Given this list of marker genes FPGT, GNPNAT1, AMDHD2 (amidohydrolase domain containing 2), ST3GAL3, NEU2, NEU4 (NCBI Gene Id 129807), NANS, ST8SIA2, ST8SIA3, GLB1, DPM2, ST6GALNAC6, NPL, GFPT2, ST8SIA4, ST3GAL4, PMM1, ST3GAL5, HK1, NUS1 (NCBI Gene Id 116150), GFPT1, SRD5A3, NANP, GMDS, FCSK, NEU3, ST8SIA5, ST3GAL2, ST6GALNAC3, GMPPA, SLC35A1, MPI, ST8SIA6, ST6GAL2, ST8SIA1, ALG5, SLC17A5, ST6GALNAC2, GMPPB, GNE, ST6GAL1, DPM3, GFUS, ST6GALNAC5, ST6GALNAC4, DOLPP1, CMAS, NAGK, ST6GALNAC1, CTSA, RENBP, SLC35C1, NEU1, UAP1, ST3GAL1, PMM2, NUDT14 (nudix hydrolase 14), DOLK, PGM3 (NCBI Gene Id 5238), DPM1, DHDDS, FUOM, DHRSX, ST3GAL6, MVD, here is a description of the gene set: Human Gene Set: REACTOME_SYNTHESIS_OF_SUBSTRATES_IN_N_GLYCAN_BIOSYTHESIS Synthesis of substrates in N-glycan biosythesis studied in species Homo sapiens